The following is a description of a gene set: species: Homo sapiens from publication Filén S, Ylikoski E, Tripathi S, West A, Björkman M, Nyström J, Ahlfors H, Coffey E, Rao KV, Rasool O, Lahesmaa R (PMID 20304822) The aim of this study was to identify genes regulated by IL-12, IL-18 and IFN-alpha during early differentiation of human Th1 cells Human Gene Set: GSE20198_IL12_VS_IFNA_TREATED_ACT_CD4_TCELL_UP Genes up-regulated in the activated CD4 T cells (48h): IL-12 versus interferon alpha., and this is the list of marker genes: PATZ1, GIPC1, ABHD1, YTHDF1, ERBB3, DYNLT2B, RCC1L, TLE4, RNF103, DHRS13, USE1, CWC25, TIMM8B, NBN, ZDHHC21, ANAPC16, STRADB, NOP10, EMC1, SLC35G1, IP6K1 (inositol hexakisphosphate kinase 1), PHPT1, VMAC, LYPLA1, CDK9, GUF1, HIGD2A, RPL18, LYRM1, CHD1L, SREBF2, CERS6, TXNL4B, EXOSC5, FBXO25, SUPT3H, SMIM7, STAT4, C10orf88, BCL7C, ERAP1, SLC39A2, MPLKIP (NCBI Gene Id 136647, M-phase specific PLK1 interacting protein), SLC25A26, ONECUT2, OTUD5, BORCS6, MACIR, CDC27, PHYHIP, APIP, ATF5, TPRA1, MRPL33, ZFR, CDKN2A, GLRX, NR2C2AP, TMEM168, SMARCC2, ALKBH5, STXBP3, FKBPL, MRPL44, EXOSC9, WDR75, MRTO4, CENPJ, DNAL1, ACOX1, RBIS, RWDD1, NSFL1C, TTC1, SRCAP (NCBI Gene Id 10847), NOP56, FUT8, LSS, MTCP1, ZC3H7A, TDP1, NAF1, GSK3B, FSTL1, DRG1 (NCBI Gene Id 4733), PHOSPHO2, DOHH, ZNF644, BRMS1L (NCBI Gene Id 84312), HNRNPH1 (NCBI Gene Id 3187), RBP1, CSNK1A1, COX15, DHX32, CRELD1, KLC1, ACD, NDUFA1, SEPTIN2, ZDHHC4, FPR2, CUTC, PPIH, QSOX2, PLGRKT, TRIM67, FRMD6, OBI1, EIF2A, NDST2, INPP5E, RETREG2, CTH, MRPL22, EIF3B, DENND11, RIT1, ZNF606, NUP85, POLR2J, LSM4, MARVELD2, NUDCD1, AGFG2, GUSB, THOC7, ZNF627, EFR3A, JARID2, KDM1A, B3GNT2, BLM, FAR1, GFM1, HDAC5, C1orf174 (chromosome 1 open reading frame 174), CEP19 (centrosomal protein 19), MAP3K20, WDR53, TMEM120A, C19orf73, PPIL3, POC5, SESTD1, TP53, F8A1, PPWD1, SLC9B2, DHX9 (DExH-box helicase 9), SETD6, ATG16L1, RAB5C, ARHGAP1, ALG14, UBE2Z, SCO1, HDAC3, RABIF, RADIL, SLC39A1, MTFR1L (mitochondrial fission regulator 1 like), IFT74, ACSL5, HDHD3, SLC2A6, EIF4A2, TMC4, EHD1, MAGI2, ZDHHC24, VTI1A, TRIM37, METTL18, OSBP, GINS1, GLRA2, ABCB4, THYN1, ARV1, TXNL1, UBQLN4, PDPR, TTC33, PTGES2, CRK, IFT57, DAP, FOXK1, SIRT4, FAM98B, SLC20A1, SMIM1, PEX3, PLEKHJ1, HBP1, PTPN22, EIF5A2, RPL3, ANAPC11 (NCBI Gene Id 51529)